The following is a description of a gene set: studied in species Mus musculus Reactome Pathway: TCF dependent signaling in response to WNT part of: Signaling by WNT electronically inferred by orthology from the curated human pathway This event has been computationally inferred from an event that has been demonstrated in another species.<p>The inference is based on the homology mapping from PANTHER. Briefly, reactions for which all involved PhysicalEntities (in input, output and catalyst) have a mapped orthologue/paralogue (for complexes at least 75% of components must have a mapping) are inferred to the other species., and this is the list of marker genes: Kremen1, Fzd8, Cav1, Pygo2, Psmb4 (NCBI Gene Id 19172), Axin2, Cby1, Lrp5, Fzd4, Psmd1, Psma3, Psma7, Wnt3a, Csnk1e, Csnk1a1, Smarca4, Psmc1, Wnt3, Hecw1, Sox7, Psma4, Psmc4, Tcf7, Psmc2, Rnf43, Sry, Xpo1, Dvl2, Sox6, Ppp2r5b, Wnt1, Psmc3, Sox2, Psma5, Psmd7, Psmb7, Ubb, Znrf3, Chd8, Dkk4, Psma6, Psmc5, Psmc6, Dkk1, Dkk2, Psmb5, Wnt8b, Csnk2b, Tert, Leo1 (NCBI Gene Id 235497), Sox4, Ash2l, Tcf7l1, Axin1, Wnt8a (NCBI Gene Id 20890), Psmd6, Pygo1, Frat1, Bcl9, Psmd12, Sost, Ep300 (E1A binding protein p300), Fzd2, Fzd6, Igfals, Tnks2, Rps27a, Psma1, Psmd13, Ppp2r1b, Psmb6, Men1, Ctnnb1, Ryk, Dvl3, Ppp2r5a, Fzd1, Dvl1, Klhl12, Rspo1, Frat2, Ppp2r5d, Smurf2, Lgr5, Rspo3, Sox17, Bcl9l, Psma2, Amer1, Kremen2, Tcf7l2, Kmt2b, Rnf146